The following is a description of a gene set: Human Gene Set: GOMF_EPIDERMAL_GROWTH_FACTOR_RECEPTOR_BINDING Binding to an epidermal growth factor receptor. species: Homo sapiens, and this is the list of marker genes: AREG, ATXN2, TNK2, AGR2, CCDC88A, GRAP, RNF126 (NCBI Gene Id 55658, ring finger protein 126), EREG, HIP1, SNX2, EGF, HBEGF, SOS1, SHC1, BTC, SLA, EPGN, SNX4, ITGA5, FAM83B, VAV2, ERBB4, SNX1, SOCS5, LINGO1, GRB2, CBLC, TGFA, ARF4, EFEMP1, MS4A1, FER, CNOT9 (NCBI Gene Id 9125), VAV3, PLSCR1